Given this list of marker genes Kras, Rapgef1, Pdgfra, Crk, Plcg1, Pdgfb, Pdgfa, Ptpn11, Stat5a, Sos1, Rasa1, Src, Hras, Stat5b, Bcar1, Grb7, Stat6, Grb2, Crkl, Nck1, Pik3cb, Pik3r2, Stat3, Pik3ca, Nck2, Pik3r1, Pdgfrb, here is a description of the gene set: Mouse Gene Set: REACTOME_DOWNSTREAM_SIGNAL_TRANSDUCTION species: Mus musculus Downstream signal transduction